The following is a description of a gene set: studied in species Mus musculus Mouse Gene Set: GOMF_OXIDOREDUCTASE_ACTIVITY_ACTING_ON_THE_CH_CH_GROUP_OF_DONORS_NAD_OR_NADP_AS_ACCEPTOR Catalysis of an oxidation-reduction (redox) reaction in which a CH-CH group acts as a hydrogen or electron donor and reduces NAD or NADP., and this is the list of marker genes: Ptgr2, Decr2, Srd5a1, Fasn, ENSMUSG00000144291, Akr1c20, Srd5a2, Srd5a3, Tm7sf2, Dus2, Blvrb, Ptgr3, Mecr, Decr1, Ptgr1, Tecr, Akr1c14, Dus4l, Dus3l, Akr1cl, Akr1b1, Pecr, Ptges2, Lbr (NCBI Gene Id 98386), Akr1d1, Dpyd, Akr1c18, Cyp2s1, Dus1l, Dhcr24, Bdh2, Dhdh, Akr1c21, Dhcr7, Akr1c6, Blvra (biliverdin reductase A), Tbxas1